Given this list of marker genes SKP2 (S-phase kinase associated protein 2), FBXO5, DZIP3, UBE2J2, LTN1, CYLD, RING1 (ring finger protein 1), TRIM32, RAD18, RNF32, SOCS2, here is a description of the gene set: from publication Stegmeier F, Rape M, Draviam VM, Nalepa G, Sowa ME, Ang XL, McDonald ER 3rd, Li MZ, Hannon GJ, Sorger PK, Kirschner MW, Harper JW, Elledge SJ (PMID 17443180) Human Gene Set: STEGMEIER_PREMITOTIC_CELL_CYCLE_REGULATORS Pre-mitotic cell cycle regulators (CDC) identified in an shRNA screen of the ubiquitin pathway components. studied in species Homo sapiens The spindle checkpoint prevents chromosome mis-segregation by delaying sister chromatid separation until all chromosomes have achieved bipolar attachment to the mitotic spindle. Its operation is essential for accurate chromosome segregation, whereas its dysregulation can contribute to birth defects and tumorigenesis. The target of the spindle checkpoint is the anaphase-promoting complex (APC), a ubiquitin ligase that promotes sister chromatid separation and progression to anaphase. Using a short hairpin RNA screen targeting components of the ubiquitin-proteasome pathway in human cells, we identified the deubiquitinating enzyme USP44 (ubiquitin-specific protease 44) as a critical regulator of the spindle checkpoint. USP44 is not required for the initial recognition of unattached kinetochores and the subsequent recruitment of checkpoint components. Instead, it prevents the premature activation of the APC by stabilizing the APC-inhibitory Mad2-Cdc20 complex. USP44 deubiquitinates the APC coactivator Cdc20 both in vitro and in vivo, and thereby directly counteracts the APC-driven disassembly of Mad2-Cdc20 complexes (discussed in an accompanying paper). Our findings suggest that a dynamic balance of ubiquitination by the APC and deubiquitination by USP44 contributes to the generation of the switch-like transition controlling anaphase entry, analogous to the way that phosphorylation and dephosphorylation of Cdk1 by Wee1 and Cdc25 controls entry into mitosis.